The following is a description of a gene set: Human Gene Set: GOBP_INTRACELLULAR_STEROL_TRANSPORT studied in species Homo sapiens The directed movement of sterols within cells., and this is the list of marker genes: PCSK9, LDLRAP1, ABCA1, RELCH, OSBP, NUS1, STARD4 (StAR related lipid transfer domain containing 4), TPCN2, SERAC1 (NCBI Gene Id 84947), MIR27B, SCP2, PIP4K2A, VPS52, SYT7, ARV1, GRAMD1C, VPS53, STAR, ANXA2 (annexin A2), VPS4A, OSBPL2, MIR185, VPS54, GRAMD1A, MIR17, ABCA2, ANXA2P2, LDLR, VPS51, CES1, TMEM97, ARL8B, NPC1, ABCG1, NPC2, GRAMD1B, TSPO2